Given this list of marker genes M2-2, N, Human respiratory syncytial virus A2, complete genome, L, HSPA8, P, M2-1, here is a description of the gene set: species: Homo sapiens The negative sense, single-stranded RNA (-ssRNA) genome of the respiratory syncytial virus (RSV) is transcribed into 10 positive sense messenger RNAs that encode 11 viral proteins. The 10 viral mRNAs, going from the 3' end, are: 1C (NS1) mRNA,1B (NS2) mRNA, N mRNA, P mRNA, M mRNA, SH mRNA, G mRNA, F mRNA, M2 mRNA, and L mRNA. Except for the M2 mRNA, each mRNA contains a single open reading frame (ORF). The two overlapping open reading frames (ORFs) of the M2 mRNA are translated into two distinct proteins, M2-1 and M2-2.<br><br>The N mRNA encodes the nucleoprotein, while the L and P mRNAs encode the large polymerase subunit and the phosphoprotein polymerase cofactor subunit, respectively, of the RNA-dependent RNA polymerase complex (RdRP). The M2-1 mRNA encodes a transcription processivity factor, while the M2-2 mRNA encodes a nonstructural protein that regulates the switch between transcription and genome replication. The SH, G and F mRNAs encode three proteins that are embedded in the viral envelope: small hydrophobic protein, attachment protein and fusion protein, respectively. The secreted isoform of G protein (sG), involved in mediation of immune evasion, and the truncated form of SH (SHt), are translated from G mRNA and SH mRNA, respectively, through the usage of an alternative start codon. The NS1 and NS2 mRNAs encode nonstructural proteins that function together to inhibit apoptosis and interferon response in infected cells. All RSV mRNAs undergo 5' capping and 3' polyadenylation, performed by the viral RdRP. For review, please refer to Battles and McLellan 2019. part of: Respiratory syncytial virus (RSV) genome replication, transcription and translation Reactome Pathway: Respiratory syncytial virus genome transcription